The following is a description of a gene set: Human Gene Set: GOBP_MITOCHONDRIAL_TRANSLATIONAL_ELONGATION The successive addition of amino acid residues to a nascent polypeptide chain during protein biosynthesis in a mitochondrion. species: Homo sapiens, and this is the list of marker genes: TSFM, GFM1, TUFM, GFM2, MRPL44